The following is a description of a gene set: species: Homo sapiens Human Gene Set: HP_ABNORMAL_CIRCULATING_CERULOPLASMIN_CONCENTRATION Abnormal circulating ceruloplasmin concentration Any deviation of the concentration of ceruloplasmin in the blood from the normal range., and this is the list of marker genes: ATP7B, CP, AP1B1 (adaptor related protein complex 1 subunit beta 1), AP1S1, ATP7A, COG2, CCDC115, TMEM199, FTH1, SLC31A1, SLC33A1